Given this list of marker genes NAF1, LAMTOR2 (late endosomal/lysosomal adaptor, MAPK and MTOR activator 2), SKIC3, TYMS, SOX10, DCT, STN1, MYO5A, NDN, PRKAR1A, PIGN, BLOC1S3, KANSL1, DTNBP1, RMRP, DSTYK, NHP2, WRN, MOGS (mannosyl-oligosaccharide glucosidase), DPP9 (NCBI Gene Id 91039), LPAR6, EDN3, FGFR3, MC1R (melanocortin 1 receptor), PAX3, USB1, LRPPRC (leucine rich pentatricopeptide repeat containing), OCA2, MITF, NPM1, LYST, UBE3A, AP3D1, TYRP1 (tyrosinase related protein 1), LIPH, KITLG, TYR, CHN1, SIM1, KRT74, HPS4, LMNA, TMCO1, ZFX, ELN, UBR1, ERCC8, TP63, MAGEL2, TTI1, PDE4D, SLC17A5, PARN, TAFAZZIN, PADI3, KIT, RPA1, AP3B1, SNRPN, CTC1, ATP7A, ZNF699, TERT, PTPN22, MAFB, HPS1, HPS3, TGM3, IFT140, ATP10A, SLC5A6, MDM2, ACD, PAH, ABCA2, EPG5, FDFT1, BLOC1S5, HPS5, CLCN7, GJB6 (gap junction protein beta 6), SKIC2, SNAI2, HRAS, PCSK1, TINF2, MLXIPL, POMC, LRMDA, POT1, ZNF469, BRCC3, DHCR7, DKC1, MLPH, MTAP, SLC45A2, EDNRB, RTEL1, WDR45, NOP10, PEPD, KRT71, TFAP2A, PRDM5, SALL4, PSMB8, FAS, TERC, WRAP53, SLC24A5, SPRTN, RAB27A, CTNS, ATM, ERCC6, RECQL4 (NCBI Gene Id 9401), HPS6, GNPTAB, INSR, KRT25, here is a description of the gene set: Human Gene Set: HP_ABNORMALITY_OF_HAIR_PIGMENTATION Abnormality of hair pigmentation An abnormality of hair pigmentation (color). studied in species Homo sapiens